Given this list of marker genes SPTSSA, ERG28, LHFPL6, RPS4Y1, BTF3, GPC1, FN1, SERPINE2, MAGED1, S100A1, MATN3, SRI, C12orf57, KRT10-AS1, SNAI2, PTGES, AOPEP, UXS1, XPOT, CHPF, BCAR1, EMP2, MTX1, COL4A2, PHPT1, PTPN14, ARL13B, NDUFA4L2, INHBA, EMP1, PKIG, MEG3, SOD3, BMP2, MYDGF, GALNT2, ATXN3, COL6A1, DCN, PLP2, RPL11, TIMM50 (translocase of inner mitochondrial membrane 50), RGS3, CNN3, CAV2, HSPG2, FBXO2, VASN (vasorin), SPON2, EI24, SDC1, SNHG32, PHLDA3, TMEM47, MGLL (monoglyceride lipase), CAV1, TMEM9, GPX8, CNMD, SCRG1, NUCB2, PTPA (NCBI Gene Id 5524), HAPLN1, CAVIN1, ANGPTL2, COL9A1, FSTL1, COX7A1, HNRNPA1L3, PRDX2, CKAP4, S100A13, TPM2, CALD1, TNFRSF11B, FAM3C, TNN, H1-0, CALU, P4HB, COL12A1, OGN (NCBI Gene Id 4969), MLLT11, CUL5, CSPG4, DAP, IGFBP7, PPP3CA, SOX4, DDR2, DLX5, WWP2, TMEM263, PRELP, ITM2C, COL2A1, MXRA8, SPIN1, C1QTNF3, AK1, CPE, MDFI, COL11A1, TATDN1, TMED1, IGFBP3, RCN1, CRIP2 (NCBI Gene Id 8112), NFIX, KDELR3, ISLR, MED21, SELENOM, YWHAQ, PRRX1, DHX15, PLAC9, CCT5, SERTAD4-AS1, PODNL1, CLEC3A, PCSK1N, RCN3, FKBP9 (FKBP prolyl isomerase 9), SDR39U1, SBSPON, PGF, TMEM14A, MATN2, MMP2, MSI2, COL11A2, KRT10, GADD45A, SLPI, COL5A2 (collagen type V alpha 2 chain), RPL7, TUBB2B, COL9A2, EFEMP2, BGN, PRDX6, ITGA10, ACAN, ENPP1, ANGPTL4, SNRPE, MFGE8, IGFBP5, STC2, PMP22, YIPF2, COL5A1, IL6ST, YIF1A, POSTN, EPB41L4A-AS1, TMEM167A (transmembrane protein 167A), CD320, OXA1L, SERPINH1, TPBG, LOXL2, SLC44A2 (solute carrier family 44 member 2 (CTL2 blood group)), FGFR1, MRPL11, SOX9, NT5E, PTN, MAP1B, RHOD, TNC, DSTN, ID4, FAM180A, MAGED2 (NCBI Gene Id 10916), OSTC, CLMP (NCBI Gene Id 79827), FBL, ACTN4, CTHRC1, DKK3, FKBP14, MED10, COL15A1, CD55, CXCL14, MGP, RPS14, SPATS2, ENAH (NCBI Gene Id 55740), CCN1, WFDC2 (WAP four-disulfide core domain 2), EIF3E (NCBI Gene Id 3646), ISOC2, FGFBP2, RASD1, CEBPG, COPS5, TMEM98, SLC39A14, ZFR, MT1M, NOL3, CRABP2, VKORC1, MYL9, MT1E, REXO2, COL1A2, NRN1, EFNA1, LOX, SRP9, CNIH4, LRRFIP2, MDK, TSC22D1, RBFOX2, AEBP1, NNMT, COMP, TRIM47, HSPB2, KDELR2, IMMP2L, TTC3, TIMP3, FERMT2, UBA2, SGCB, BCL7C, COL9A3 (NCBI Gene Id 1299), SMIM7, EEF1A1, PYCR1, CDO1, IFT22, TPM1, PEMT, PRDX4, CILP2, SETD9, RPS10, COL6A3, PCOLCE, RNPS1, CRYAB, C11orf96, RCN2, P4HA2, GJA1, SDC4, FMOD, UAP1, ABT1, TNNT3, C5orf15, PAGE2B, SSR2, TM4SF1, SRPX, NDUFAF2, COL3A1, AQP1, COL1A1, PFN2, FKBP10, PERP, S100P, ZFAND1, RPL9, ZFYVE21, ID1, PCOLCE2, MIA, SOX8, STC1, CCN2, MAP2K7, PRSS23, UGP2, EDIL3, MEST, FAM114A1, PSMB5, here is a description of the gene set: species: Homo sapiens Human Gene Set: SU_HO_CONV_CENT_CHONDROSARCOMA_LEUKOCYTE_C3_SKELETAL_PROGENITOR_LIKE_CELL from publication Su Z, Ho JWK, Yau RCH, Lam YL, Shek TWH, Yeung MCF, Chen H, Oreffo ROC, Cheah KSE, Cheung KSC (PMID 38267611) A small skeletal progenitor-like cell population (2-12%) was found in Leuk. SP expressed human skeletal stem cell markers (PDPN+, CD164+, NT5E+, and MCAM). Moreover, SP markers were enriched in gene ontology terms relevant to multipotency. The transformation of benign lesions to malignant tumours is a crucial aspect of understanding chondrosarcomas, which are malignant cartilage tumours that could develop from benign chondroid lesions. However, the process of malignant transformation for chondroid lesions remains poorly understood, and no reliable markers are available to aid clinical decision-making. To address this issue, we conducted a study analysing 11 primary cartilage tumours and controls using single-cell RNA sequencing. By creating a single-cell atlas, we were able to identify the role of endoplasmic reticulum (ER) stress in the malignant transformation of conventional central chondrosarcomas (CCCS). Our research revealed that lower levels of ER stress promote chondrosarcoma growth in a patient-derived xenograft mouse model, while intensive ER stress reduces primary chondrosarcoma cell viability. Furthermore, we discovered that the NF-?B pathway alleviates ER stress-induced apoptosis during chondrosarcoma progression. Our single-cell signatures and large public data support the use of key ER stress regulators, such as DNA Damage Inducible Transcript 3 (DDIT3; also known as CHOP), as malignant markers for overall patient survival. Ultimately, our study highlights the significant role that ER stress plays in the malignant transformation of cartilaginous tumours and provides a valuable resource for future diagnostic markers and therapeutic strategies.